Given this list of marker genes ITM2A, ARHGAP29, INPP5F, ITGAM, CYP51A1, PTGER4, PJA2, ARHGEF10, PPM1J, CBFA2T2, SC5D, TBC1D4, CNST, CERS6, TGFBR1, SFT2D2, RCAN3, DUOX1, PFN2, NCF2, MAP3K5, RTF1, GMEB2, TASP1, FOXP3, CTLA4, ARSG, RAD18, SLC4A7, SELENOP, CAPG, ACVR2A, XBP1, CBX6, NXPE3, PRR12, CD9, TEX2, CRMP1, TMEM64, SLFN5, TGFBR3 (transforming growth factor beta receptor 3), ZBTB7B, STON1, BTLA, CTSE, RNF19A (ring finger protein 19A, RBR E3 ubiquitin protein ligase), LGMN, ST8SIA6 (ST8 alpha-N-acetyl-neuraminide alpha-2,8-sialyltransferase 6), RANBP10, GPR183 (NCBI Gene Id 1880), NCMAP, P2RX7, TNFRSF25, MTHFD2, C2orf68, SGMS1, EPHB6, CRLF3, MYOF, TUBB2B, MIF4GD, DCUN1D4, E2F2, FADS6, DNAJB5, ADH1C, SNAP47, CKB, BTBD8, IBTK, SAV1, SLC25A23, PCK2, IGSF23, UCP2, C15orf39 (chromosome 15 open reading frame 39), CD200R1, NUP153, CAPN3, PSEN2, ITM2C, LNX2, IRF6, ST6GAL1, RB1, TENT5C, ACSL3, L1CAM, CD81, HNRNPLL, AHCYL2, HEMK1, LATS2, MTSS1, CD200, DHRS13, TNFSF11, ITIH5, TMEM65, CISH, SFMBT2, CDH3, CIRBP, IZUMO1R, CRLF2, CD247, IL2RA, FASLG, BCL11B, CD4, SLC48A1, RSU1, TMEM164, ARHGAP31, TRIOBP, TWSG1, MAPKAPK3, ZNRF1, GPR83, DSEL, KIF1B, GLOD5 (glyoxalase domain containing 5), AKT3, LIMA1, PDLIM4, ZNF287, GCAT, RCOR3 (REST corepressor 3), STMN1, PFKFB4, ITGB3, VAV3, CYTIP, BMP2K, TIAM1, CDON, HIF1A, NRP1, TRIB2, P2RX4, IGFBP4, SSH1, FKBP1A, ACVRL1, SLC5A3 (NCBI Gene Id 6526), EPS15, RAB27A, CD28, TRARG1, MICU1, PRG4 (NCBI Gene Id 787), MAN1C1, TMEM154, MTMR3, MAPK11, PLXND1, SLC25A24, NSDHL, IGF2R, TNFRSF4, CD5, STAM2, ATL1, FNIP1, TRAT1, ASS1, IFI30, RBL2, TSPAN32, H1-0, UXS1, SYTL2, TESC, MCUB, RAMP3, BAG3, TRAPPC1, SDCBP2, ABCG2, MLEC, DAPK1, RUFY3, SKI, SYPL1, FLT3LG, PRMT2, ASAP1, MYO6, CNOT6, ATXN7L1, FLOT2, FBXO42, GLCCI1 (glucocorticoid induced 1), SAMSN1, ECM1, MYO18A, RNF216, PKP3, KBTBD11, here is a description of the gene set: Genes up-regulated in CD4 T cells treated with HDAC inhibitors: 2h versus 12h. studied in species Homo sapiens from publication Wang Z, Zang C, Cui K, Schones DE, Barski A, Peng W, Zhao K (PMID 19698979) Human Gene Set: GSE15735_2H_VS_12H_HDAC_INHIBITOR_TREATED_CD4_TCELL_UP Histone acetyltransferases (HATs) and deacetylases (HDACs) function antagonistically to control histone acetylation. As acetylation is a histone mark for active transcription, HATs have been associated with active and HDACs with inactive genes. We describe here genome-wide mapping of HATs and HDACs binding on chromatin and ﬁnd that both are found at active genes with acetylated histones. Our data provide evidence that HATs and HDACs are both targeted to transcribed regions of active genes by phosphorylated RNA Pol II. Furthermore, the majority of HDACs in the human genome function to reset chromatin by removing acetylation at active genes. Inactive genes that are primed by MLL-mediated histone H3K4 methylation are subject to a dynamic cycle of acetylation and deacetylation by transient HAT/HDAC binding, preventing Pol II from binding to these genes but poising them for future activation. Silent genes without any H3K4 methylation signal show no evidence of being bound by HDACs.